The following is a description of a gene set: The SLC26A1 and genes encode sulfate transporter proteins that facilitate sulfate uptake into cells, critical in cartilage for sulfation of proteoglycans and extracellular matrix organization. Defects in SLC26A2 result in impaired SO4(2-) transport leading to insufficient sulfation of cartilage proteoglycans. Defective SLC26A2 is implicated in the pathogenesis of a spectrum of autosomal recessive human chondrodysplasias. Severity of symptoms range from mild (diastrophic dysplasia; MIM:222600), intermediate (atelosteogenesis type II; MIM256050) to severe (achondrogenesis type 1B; MIM:600972). species: Homo sapiens Reactome Pathway: Defective SLC26A2 causes chondrodysplasias part of: Diseases associated with glycosaminoglycan metabolism; SLC transporter disorders, and this is the list of marker genes: SLC26A2